Given this list of marker genes SAMD9, CFAP52, USP15, PPP2CA, YAE1 (YAE1 maturation factor of ABCE1), CADM2, MYRF, CXXC5, FAM171A1, SKIC3, TK2, ASPH, SLC2A1, EYS, PNPLA8, GNG2, CALCR, MYO3B, GLUL, AP3S1, TSLP, NIPBL, TBC1D12, COL3A1, PCNP, CFAP53, PURA, AHCTF1, CYCS, RBFOX2, BZW1, TAF1, TMEM200A, AHR, ZNF250, PGBD4, PPP4R3B, MAK16, IGF2BP2, ACTR1A, KIRREL1 (kirre like nephrin family adhesion molecule 1), PCDHB3, BMAL2, KRT40, MLLT11, MSL1, GNPTG, EXO1, SUMO1, WDR11, AP1S3, XPO7, LRRN3, TRIM27, here is a description of the gene set: from publication Chen Y, Wang X (PMID 31504780) Human Gene Set: MIR4653_3P Genes predicted to be targets of miRBase v22 microRNA hsa-miR-4653-3p in miRDB v6.0 with MirTarget v4 prediction scores > 80 (high confidence targets). species: Homo sapiens